The following is a description of a gene set: part of: Creation of C4 and C2 activators studied in species Mus musculus Reactome Pathway: Lectin pathway of complement activation electronically inferred by orthology from the curated human pathway This event has been computationally inferred from an event that has been demonstrated in another species.<p>The inference is based on the homology mapping from PANTHER. Briefly, reactions for which all involved PhysicalEntities (in input, output and catalyst) have a mapped orthologue/paralogue (for complexes at least 75% of components must have a mapping) are inferred to the other species., and this is the list of marker genes: Mbl2, Colec11, Masp2, Masp1, Colec10, Fcnb, Fcna